Given this list of marker genes Klf2, Btg2, Dusp1, Jund, Peli1, Rgs1, Fos, Zfp36l1, Jun, Tsc22d3, here is a description of the gene set: from publication Cui A, Huang T, Li S, Ma A, Pérez JL, Sander C, Keskin DB, Wu CJ, Fraenkel E, Hacohen N (PMID 38057668) Genes negatively differentially expressed in cell type: NK cell upon treatment with cytokine: FasL in mouse lymph nodes in vivo. studied in species Mus musculus Mouse Gene Set: CUI_NK_CELL_FASL_RESPONSE_DN Cytokines mediate cell-cell communication in the immune system and represent important therapeutic targets. A myriad of studies have highlighted their central role in immune function, yet we lack a global view of the cellular responses of each immune cell type to each cytokine. To address this gap, the authors created the Immune Dictionary, a compendium of single-cell transcriptomic profiles of more than 17 immune cell types in response to each of 86 cytokines (>1,400 cytokine-cell type combinations) in mouse lymph nodes in vivo. A cytokine-centric view of the dictionary revealed that most cytokines induce highly cell-type-specific responses. For example, the inflammatory cytokine interleukin-1β induces distinct gene programmes in almost every cell type. A cell-type-centric view of the dictionary identified more than 66 cytokine-driven cellular polarization states across immune cell types, including previously uncharacterized states such as an interleukin-18-induced polyfunctional natural killer cell state.